The following is a description of a gene set: Any process that modulates the frequency, rate or extent of epithelial cell migration. Human Gene Set: GOBP_REGULATION_OF_EPITHELIAL_CELL_MIGRATION species: Homo sapiens, and this is the list of marker genes: EPPK1, MACIR, EVL, MCC, ENPP2, IFNG, ITGA2, PTPRR, IQSEC1, VIL1, MIR221, MIR379, MARVELD3, EPB41L5, ITGA3, PLCG1, SOX9, MIR222, TACR1, INSL3, PTK2, CLASP1, TGFB2, PFN1, HAS2, CORO1C, MACF1, PLCG2, ARF6, RAB11A, ARSB, HDAC6, CLASP2, HBEGF, DOCK1, EPB41L4B, FGF10 (NCBI Gene Id 2255, fibroblast growth factor 10), RTN4, PPM1F, DUSP10, DOCK5, CD63, ARHGAP5, IRS2, PRKCE, RREB1, TGFBR2, CAPN7, PTPN23, RAB25, PFN2, MMP9, JUN, MTOR, TAC1, ADAM9, MAP4K4 (NCBI Gene Id 9448), PTEN, MAPRE2, DAB2IP, SRC, IL4, GLIPR2, BMPR2, SASH1 (NCBI Gene Id 387570), FGF7, ADIPOR1, MIR130A, CTSH, PTPRG, TACSTD2, HIF1A